The following is a description of a gene set: part of: Cytoprotection by HMOX1 Reactome Pathway: Regulation of HMOX1 expression and activity Heme oxygenase 1 (HMOX1) is regulated at the level of gene transcription, mRNA translation, localization and degradation. Its gene is often activated under a wide range of stressful conditions. The transcriptional control of HMOX1 is determined by inducible regulatory elements localized in the 5′ region of the promoter, so called antioxidant response elements (ARE).<br><br>AREs on the HMOX1 gene are ultimately controlled by the enhancing NFE2L2:MAFK dimer and the repressing BACH1:MAFK dimer, both of which are influenced by a multitude of processes. Less specific enhancement occurs via AP-1 (FOS:JUN) dimers.<br><br>HMOX1 activity depends on dimerization in the ER membrane. Its membrane localization is abandoned by cleavage of the membrane domain by HM13. The resulting soluble enzyme is found in the cytosol, mitochondria, and the nucleus. species: Homo sapiens, and this is the list of marker genes: MAFK, HMOX1, BACH1, HM13, NFE2L2